The following is a description of a gene set: Genes predicted to be targets of miRBase v22 microRNA hsa-miR-20a-3p in miRDB v6.0 with MirTarget v4 prediction scores > 80 (high confidence targets). Human Gene Set: MIR20A_3P from publication Chen Y, Wang X (PMID 31504780) studied in species Homo sapiens, and this is the list of marker genes: MND1, NF1, CHN2, UGT8, AK6, MTMR7, ONECUT2, ZBTB38, SEC23IP, ADAMTS6, SCGB2B2, MMGT1, EGFLAM, KCNA2, DARS2, TMEM67 (transmembrane protein 67), ZNF853, DDX17, SIAE, DNAJC7, HDAC9, SH3PXD2A, NCOA7, RAD51, TDG, GALNT3, SZT2, NUP214, WDR47, KLRC3, MLLT3, SPATA2, BAHD1 (NCBI Gene Id 22893), CPEB2, MAGEB1, PRKCE, PI15, OTUD1, SLC39A12, SYNPR, PDCD6IP, CCL4, CTDSPL2, GPATCH2, PRSS12, SPOPL, RGL1, NPM1, EHMT1, ZDHHC6, PURA, CREBZF, TFDP3, FAM241A, APOL2, ZBTB20, CACNB4, SLC38A2, RMND5A (required for meiotic nuclear division 5 homolog A), UNC13C, ACSM5, GADL1, ATP2B1, RORA, TOX, KCNK2, BMPR2, VGLL2, DYRK1A, HTATSF1, MBTD1, KATNA1, EIF2AK3, OTUD4, C14orf28, DNAJC1 (DnaJ heat shock protein family (Hsp40) member C1), R3HCC1L, PTPN21, YTHDC2, ZC3H7B, MRPS30, TLN1, SOCS5, FBXO34 (NCBI Gene Id 55030), ADAM10, ALG2 (ALG2 alpha-1,3/1,6-mannosyltransferase), FIGN, TENM4, YOD1, CPEB3, ERI1, RHBDL3, TET2, ANKRD50, PPM1E, CDKL5, KIF13A (kinesin family member 13A), CPEB4, GORASP2, ATRNL1, BTAF1, ACVR2B, BEND3, CDH13, KLF9, ASXL3, WAPL, CSNK2A1, RGS7, SEMA6D, USP12, ANKRD1, HERPUD1, VPS37B, SUPT7L, PPP4R3B, PLXNA4, CNTN5, REXO4, ALOX5AP, SLAIN2, NECTIN3, SPRY1, TMEM199, SLC22A15, POU3F2, ARF6, LILRB2 (leukocyte immunoglobulin like receptor B2), IAH1, CSF2RA, SENP1, CNTNAP1, ST8SIA6 (ST8 alpha-N-acetyl-neuraminide alpha-2,8-sialyltransferase 6), SMAD3, PCF11, DCAF12, ZNF695, CTTNBP2NL, USP27X, RNF214, ZEB2, RBM39, RAB5A (NCBI Gene Id 5868), CYB5B, BCL11A, RHNO1, DCP2, BRD10, ONECUT1, IMPG2, PHIP, DR1, NUDT12, RNF19A, TMEM258, GPR85, CILK1, GTF2H1, SLC9A7 (NCBI Gene Id 84679), RASSF8, EXOC4, ZNF615, VCPIP1, PCMTD1, ZNF518A, ZNF268, ERICH2 (glutamate rich 2), GABRG1, SLC7A14, CEPT1, HMGN2 (NCBI Gene Id 94860), DTHD1, TMED2, SATB1, EZH2, CADM2, RET, GRB10, FBN2, SCN8A, CAPN14, REEP5, PLEKHG1, LMO7, NUFIP1, MPDZ, GNAZ, ZDHHC21